The following is a description of a gene set: Reactome Pathway: Phospholipid metabolism Phospholipids contain a polar head group and two long-chain fatty acyl moieties, one of which is generally unsaturated. The head group is a glycerol or serine phosphate attached to a polar group such as choline. These molecules are a major constituent of cellular membranes, where their diverse structures and asymmetric distributions play major roles in determining membrane properties. The four major classes of phospholipids in human plasma membranes are phosphatidylethanolamine, phosphatidylserine, phosphatidylcholine, and sphingomyelin. The first three are derivatives of glycerol while sphingomyelin is a derivative of serine.<p>Here, pathways for the metabolism of glycerophospholipids, phosphphatidylinositol (PI), and sphingolipids are annotated. species: Homo sapiens part of: Metabolism of lipids, and this is the list of marker genes: PTDSS1, PLA2G6, GPAM, CPNE1, LIPH, PCYT2 (NCBI Gene Id 5833), LPIN2, CSNK2A2, PIP4K2B, PTEN, DGAT2, INPP5J, PEMT, RAB4A, PNPLA6, MTMR12, PTPN13, PI4K2A, GPCPD1, PLA2G1B, MTMR9, GNPAT, AGPAT1 (1-acylglycerol-3-phosphate O-acyltransferase 1), GDPD1, MBOAT7, TNFAIP8L1, PIP4K2A, MGLL, CPNE6, PLEKHA4, ARF3 (NCBI Gene Id 377), CPNE7, INPP5D, PIK3C2G (NCBI Gene Id 5288), PCYT1A, PLA2G2E, OCRL, PLA2R1, SBF1, ARF1, LPCAT2, GPD1L, MTMR6, PLAAT4, DDHD2, PI4KA, MTMR2, PIK3R3, MTMR10, SLC44A2, BCHE, TMEM86B, INPP4A, PIK3R1, TNFAIP8, TPTE, GDE1, PLD1, PLA2G4E, AGPAT2, PNPLA8, GDPD3, PIP4P1, CHKB, DGAT1, PLEKHA2, MBOAT2, DGAT2L6, MTMR8, PIP5K1B, CSNK2B, ENPP6, PISD, PIKFYVE, PIK3C2A, PLEKHA1, PIK3R2, PLA2G3, PLA2G12A, ETNK1, PLBD1, PIP5K1A (phosphatidylinositol-4-phosphate 5-kinase type 1 alpha), MIGA1 (mitoguardin 1), PIK3CB, AGPAT5, PLB1, GDPD5, STARD7, PIP5K1C (NCBI Gene Id 23396), PLEKHA8, PLA1A, SLC44A5, LCLAT1, PITPNB, PLA2G15, SLC44A4, LIPI, TAFAZZIN, OSBPL5, CHKA, CDS2, BMX, HADHA, AGPAT3, PLA2G5, INPP5K, PNPLA3 (NCBI Gene Id 80339), PLA2G2A, PIK3CA, INPP5E, MIGA2, ACP6, PGS1, SBF2, MTMR14, SELENOI, LPIN3, GPAT2, CPNE3, ACHE, PLA2G4A, LPCAT3, PIK3C2B, SLC44A1, PLEKHA3, PLA2G2F, ABHD3, MTMR1, PLAAT2, GPAT3, RAB14, OSBPL10, PNPLA7, PI4KB, INPPL1, LPCAT1, PIK3R6, INPP4B, STARD10, PLA2G4B, PNPLA2, PIP4K2C, PLEKHA5, PLA2G10, PLA2G4F, MTMR3, CDS1, PIK3R4, VAC14, PLAAT5 (phospholipase A and acyltransferase 5), CEPT1, FIG4, CHPT1, MTM1, PLA2G2D, INPP5F, GPD1 (glycerol-3-phosphate dehydrogenase 1), CRLS1, PLAAT1, SYNJ1, SLC44A3, OSBPL8, PIK3R5, GPAT4, CHAT, PLD2, AGPAT4 (1-acylglycerol-3-phosphate O-acyltransferase 4), PIK3C3, SYNJ2, LPIN1, PLD3 (phospholipase D family member 3), LPGAT1, PTPMT1, ETNPPL, PTDSS2, PLEKHA6, ABHD4, HADHB, PGP, PHOSPHO1, AWAT2, AGK (acylglycerol kinase), TNFAIP8L3, SACM1L, MBOAT1, PI4K2B, GPD2, CDIPT, DDHD1, MFSD2A, PITPNM3, PLAAT3, PLA2G4D, PITPNM2, PCYT1B, PITPNM1, PIK3CG, TPTE2, TNFAIP8L2, ETNK2, PCTP, RUFY1, MTMR4, CSNK2A1, ALPI, PLD6, PLD4, PLA2G4C, LPCAT4, RAB5A, MTMR7, PIK3CD